Given this list of marker genes NOS3, NOSIP, here is a description of the gene set: studied in species Homo sapiens Reactome Pathway: NOSIP mediated eNOS trafficking eNOS-interacting protein (NOSIP) is a 34-kDa nucleocytoplasmic shuttling protein that binds to the COOH-terminal region (amino acids 366-486) of the eNOS oxygenase domain. This protein association promotes translocation of eNOS from the plasma membrane caveolae to the cytoskeleton and inhibits eNOS activity. Studies have found that NOSIP accumulates in the cytoplasm specifically during the G2 phase of the cell cycle. part of: Metabolism of nitric oxide: NOS3 activation and regulation